Given this list of marker genes SLC26A4, TG, SLC5A8, SLC26A7, ANO1, KCNQ1, SLC5A6, SLC5A5, MFSD8, here is a description of the gene set: The directed movement of iodide into, out of or within a cell, or between cells, by means of some agent such as a transporter or pore. Human Gene Set: GOBP_IODIDE_TRANSPORT studied in species Homo sapiens